Given this list of marker genes GABPB2, GET4, NT5DC1, SETBP1, KIF9, SUMO1, AAK1, DIXDC1, ZDHHC21, DERL1, SEC31A, AFTPH, ARID1A, KLHL28, SLC1A1, PJA1, VAV2, SGMS1, PBRM1, KDM2A, CCNA2, ZC3H12C, CD96 (NCBI Gene Id 337949), USP54, PRG2, FAR1, FAM169A, ZNF805, PBLD, SDR42E1, NAA30, ZBTB38, TIPARP, SRSF10 (serine and arginine rich splicing factor 10), PABPC4, LAMC1, DNMT3A (DNA methyltransferase 3 alpha), TMEM132B, TNRC6C, PLA2G4E, ARNT, RETREG2, ABHD17B, DNAL4, B4GALT6, TMEM33, MYEF2, ATF7IP, FBXO45, CCDC88A, AMMECR1, ZMYM2, NTRK3, TMEM120A, OPRM1, ICA1L, SEC61G, ABTB2, ZNF292, SPAG9, CD164, UNC5B, TNFSF10, CNN2, IRF2BP2, ZMAT3, ZC3H12B, USP38, BNC2, TBC1D23, IL1RAP, ABHD3, RAB39B, NKRF, MFSD14B, SNX27, SLC15A1, TAF7L, ALKBH5, RBM26, C2CD2, ATP8A2 (NCBI Gene Id 51761), STRN, TCAIM, XKRX, RORA, BCDIN3D, TFRC, RCN2, SLITRK6, RRN3, CDK17, FOXP2, TBL1XR1, ATP13A3, BOD1L1, BEND7, RAVER1, PTBP3, ONECUT2, DENND4C, ETS1 (NCBI Gene Id 2113), TMEM63B, KHDRBS1, GNG12, CEP85L, PPP4R4, SEMA6D, MDM2, FAM168A, KMT2C, CNOT7, RASSF3, NEB, CEBPZOS, WNK3, NPR3, CPEB2, ERCC3, SLC39A14, P2RX7, UBAP1, SOX1, UGDH, KAT6B, PRPF40A, TFDP2 (NCBI Gene Id 7029), CHD4, GABRR2, MSN, HUNK (NCBI Gene Id 30811), RFX3, KANK2, CRIPT, ACAD11, ZNF217 (zinc finger protein 217), PNISR, SMAD1 (NCBI Gene Id 4086), CCDC47, TTC28, CREBBP, SCN3A, SLC7A11, KCNAB1, BMPR1A, PDIA6, DTD1, MYO5A, MITF, TOM1L1, BAHCC1, TP53BP1, WDR77, SAMD13, OTUD7B, RABEP1, JADE1, COL4A1, GAB1, OGT, SLC25A30, SGIP1, OTUD3, B3GALNT2, TM9SF3, CLASP1, MINDY3, SVBP, SLC25A36, ROBO1, TGFBR1, RAF1, SMG7, SYNE2, PI4K2A, QKI, LIN28B, SORCS1 (NCBI Gene Id 114815), MIER3, IGF1R, BDH2, RNF169, MAPRE1, PPP1R3C, PSPC1, NHLH2, MIB1, PARP12, NUFIP2, PRR14L, RBM7, MARCHF4, MEIOC, TSNAX, RGS7BP, UNC5A, ORMDL1, NR2C1, NPC1, ANKRD28, YPEL4, ATAD2B, CTTN, RCE1 (NCBI Gene Id 9986), PPP3CB (NCBI Gene Id 5532), MAN2A1, RNF185, NCOA2, ZFAND5, RACGAP1, ANO1, SNRPG, PCBP2, NUDT15, RBM14, MLLT1, RNF103, SETD5, SH3RF1, XIAP, RMDN1, VAPA, BICD2, HDGFL3, USP3, CLGN, NKX2-1, BRWD1, PCBP1, ZNF704, RNF212B, DCP2, CIRBP, TRIO, SSB, ARAP3, SLC10A7, PUF60, ANP32E, MBTD1, DLC1, PPP1R14B, RNLS, KALRN, TOX3, BCL11B, LCP2, TYRP1, APPL2, SYNCRIP, AZIN1, CPEB1, RASSF5, TEAD3 (TEA domain transcription factor 3), ARHGAP29, MACC1, DPY19L1, LRP1B, RPS27A, VPS35, MEX3C, here is a description of the gene set: from publication Chen Y, Wang X (PMID 31504780) Human Gene Set: MIR548AS_3P species: Homo sapiens Genes predicted to be targets of miRBase v22 microRNA hsa-miR-548as-3p in miRDB v6.0 with MirTarget v4 prediction scores > 80 (high confidence targets).